Given this list of marker genes AKR1C3, CREB1, H6PD, DAB2, BMP2, GPRC6A, PPTC7, DKKL1, CLCN2, BMP6, GGCX, ADM, WNT4, SIRT5, PRKG1, BMP5, DGKQ, ADCK2, DKK3, REST, EGR1, BGLAP, here is a description of the gene set: studied in species Homo sapiens Any process that modulates the frequency, rate or extent of the chemical reactions and pathways resulting in the formation of a ketone, carried out by individual cells. Human Gene Set: GOBP_REGULATION_OF_KETONE_BIOSYNTHETIC_PROCESS